Given this list of marker genes XIAP, UBC, TCF7L1 (transcription factor 7 like 1), TLE4, BCL9, MEN1, TLE2, LEF1, UBB, PYGO1 (pygopus family PHD finger 1), SOX7, CBY1 (chibby 1, beta catenin antagonist), TLE3 (NCBI Gene Id 7090), ASH2L, CTNNBIP1, APC, SOX13, CHD8, SRY, BCL9L, AKT2, SOX6, UBA52, SOX4, YWHAZ, TCF7, AKT1, SOX17, RPS27A, XPO1, BTRC, SOX3, CTNNB1, KMT2D, TCF7L2, PYGO2 (pygopus family PHD finger 2), TLE1, SOX2, CTBP1, SOX9, RBBP5, HDAC1, here is a description of the gene set: Human Gene Set: REACTOME_DEACTIVATION_OF_THE_BETA_CATENIN_TRANSACTIVATING_COMPLEX Deactivation of the beta-catenin transactivating complex species: Homo sapiens